Given this list of marker genes ARPC1AP4, SEPTIN11, BIN2P1, HNRNPD, C4orf36, LINC00989, ART3, FRAS1, LINC02469, BMP2K, CNOT6L, G3BP2, LINC01088, FGF5, NKX6-1, RNU6-469P, CDKL2 (cyclin dependent kinase like 2), ANTXR2, PAQR3, ENSG00000199857, NAA11, THAP6, CCDC158 (coiled-coil domain containing 158), HNRNPA3P13, PRDM8, KPNA2P1, PRKG2, CXCL9, CXCL10, RPSAP39, FAM47E, MIR548AH, SERBP1P5, FAM47E-STBD1, THAP9-AS1, VAMP9P, RNU6-615P, SLC25A14P1, ARHGAP24, MTCYBP44, PRDM8-AS1, SCD5, LINC00575, RN7SL552P, NUP54, CFAP299, LIN54, HNRNPDL, BMP3, SHROOM3, TMEM150C, PTPN11P5, RN7SKP48, RNU6-1187P, MIR575, ODAPH, COQ2, ENOPH1, LINC01094, CCNI, LINC02483, PLAC8, MICOS10P4, RN7SL127P (RNA, 7SL, cytoplasmic 127, pseudogene), RPL7AP26, AFF1, WDFY3, HIGD1AP13, GK2 (glycerol kinase 2), IGBP1P4 (IGBP1 pseudogene 4), CXCL11, RNU6-774P, TXNP6 (thioredoxin pseudogene 6), HPSE, NPM1P41, SNX5P1, SOWAHB, TECRP1, GPAT3, PRKG2-AS1, MIR4450, CXCL13, RPL36P8, MAPK10-AS1, RASGEF1B, USO1, MAPK10, SNORD42, RNU6-499P, WDFY3-AS2, MIR4451, PPEF2, ABRAXAS1, NAAA, COPS4, HELQ, RN7SKP96, RCHY1, RNU6-1000P, SDAD1-AS1, PCAT4, SLC10A6, RNU5A-2P, LINC02994, SEC31A, C18orf21P1, THAP9, WDFY3-AS1, RPL30P5, ENSG00000309278, MRPL1, HNRNPA1P56, BMP2K-DT, SHROOM3-AS1, RPL3P13, STBD1 (starch binding domain 1), RPL6P13, HMGB1P44, RNU6-145P, ANXA3 (NCBI Gene Id 306), COX5BP1, HNRNPD-DT, SCARB2, RPL7P17, OR7E94P, PTPN13, MIR4452, RPL36AP18, SDAD1, CDS1, RNU2-16P, CCNG2, MRPS18C, here is a description of the gene set: species: Homo sapiens Human Gene Set: chr4q21